Given this list of marker genes PIGX, CYRIB, NACC2, GPN1, CES1, NDUFA3, TKT, C9orf78, MRPL45, NDUFA5, CIAO2A, MRPL52, TAF9, EIF4EBP1, CKAP5, NMT1, MRPL23, EBP, PARK7, HDDC2, LYRM2, SNRNP27, GTF2A2, CALB1, FKBP3, ANXA1, TOMM5, NUDT16L1, CAT, PPP2R5C, VPS29 (VPS29 retromer complex component), CD320, HNRNPA1L2, FIBP, CYB5B, PC, C17orf49, POLR3K, REX1BD, NDUFB8, NDUFA2, PSMG4, PCCB, PPIH, TXNDC17, GUK1, SNRPD2, OGFR, NAB1, GPX4, NDUFB5, DBI, ATP5F1E, MIEN1, DPM3, M6PR, PSME2, NDUFV3, CHMP2A, PLAC9, UQCR10, LGALS1, ROMO1, CHRAC1, PEX7, PPIB, COA3, ACYP2, UBL5, PQBP1, ETFB, ANAPC13, SNX10, C1D, RPP30, SEM1, NAA38, MRPL28, MRPL11, SNRPE, NDUFS2, DBNL, DAP3, HNRNPL, LSM3, PSMA6, PSMA5, SEC61G, RBM14, COA6, DYNLRB1, CCND1, CSRP1, MRPL13, ANXA2, POLE3, EMC6, ATP5PF, B9D1, ATP5MJ, CCZ1 (NCBI Gene Id 51622), COX6A1, UQCR11, NEDD8, CUEDC2, RELB, TAGLN2, COX5B, NCBP2, HNRNPH2, DAP, ECH1, RAB28, TCF19, MRPL27, SSNA1, ARMCX2 (NCBI Gene Id 9823), PAFAH1B3, MRPS18A, CSRP2, S100A6, ESD, PRPSAP2, H2AZ1, NDUFC1, UQCRC2, TSEN34, MRPS33, SUMO3, COMMD1, POLD3, ELOF1, MTMR9, NDUFB11, TMED3, BUD31, NDUFA13, ILVBL, REEP5, PDCD5, MRPL18, COX16, PMPCB, CYBA, ATP5PO, MRPL35, LSM8, PPP1R7, NDUFA9, DGCR6, ABCC1, GSR, GSTM3, FMC1, S100A10, ELOB, LAMTOR5, RBM3, PSAT1, LAGE3, IFNGR2 (interferon gamma receptor 2), ATP5MK, FAM3C, DNAJC15 (DnaJ heat shock protein family (Hsp40) member C15), TIMM8B, TMEM205, SNRPG, ERG28, UQCRB, PRDX2, MICOS13, COX7B, SLC35B2, SMTN, CETN3, CUTA, SELENOF, SF3B5, here is a description of the gene set: Genes co-regulated in uterus during a time course response to progesterone: SOM cluster 13. studied in species Mus musculus Human infertility and recurrent pregnancy loss caused by implantation defects are poorly understood. Hoxa-10-deficient female mice have severe infertility and recurrent pregnancy loss due to defective uterine implantation. Gene expression profiling experiments reveal that Hoxa-10 is an important regulator of two critical events in implantation: stromal cell proliferation and local immunosuppression. At the time of implantation, Hoxa-10 mediates the progesterone-stimulated proliferation of uterine stromal cells. Hoxa-10 mutants express a stromal cell proliferation defect that is accompanied by quantitative or spatial alterations in the expression of two cyclin-dependent kinase inhibitor genes, p57 and p15. Hoxa-10 deficiency also leads to a severe local immunological disturbance, characterized by a polyclonal proliferation of T cells, that occurs in place of the normal progesterone-mediated immunosuppression in the periimplantation uterus. Human Gene Set: YAO_TEMPORAL_RESPONSE_TO_PROGESTERONE_CLUSTER_13 from publication Yao MW, Lim H, Schust DJ, Choe SE, Farago A, Ding Y, Michaud S, Church GM, Maas RL (PMID 12554760)